The following is a description of a gene set: Human Gene Set: HP_RESPIRATORY_ARREST Respiratory arrest species: Homo sapiens, and this is the list of marker genes: TXNDC15, AGRN, SCO2, CPT2, SLC2A10, GET3, SLC25A1, AFF3, COL2A1, SLC25A20, SLC6A5, CHAT, KIT, HTRA2, DCTN1, SLC18A3, MYO9A, SLC5A7, SYT2, COL13A1 (collagen type XIII alpha 1 chain), VAMP1, SNAP25, TSPYL1, ACADVL, ADGRG6, MYL2, LAMP2, DDC, GPX4, MTFMT